Given this list of marker genes MRM2, TFB1M (transcription factor B1, mitochondrial), MRM1, MT-RNR1, NSUN4, MRM3, MT-RNR2, MTERF4, here is a description of the gene set: species: Homo sapiens Human Gene Set: REACTOME_RRNA_MODIFICATION_IN_THE_MITOCHONDRION rRNA modification in the mitochondrion